The following is a description of a gene set: Mouse Gene Set: CUI_CDC1_IL11_RESPONSE_UP studied in species Mus musculus Genes positively differentially expressed in cell type: cDC1 (conventional dendritic cell type 1) upon treatment with cytokine: IL-11 in mouse lymph nodes in vivo. from publication Cui A, Huang T, Li S, Ma A, Pérez JL, Sander C, Keskin DB, Wu CJ, Fraenkel E, Hacohen N (PMID 38057668) Cytokines mediate cell-cell communication in the immune system and represent important therapeutic targets. A myriad of studies have highlighted their central role in immune function, yet we lack a global view of the cellular responses of each immune cell type to each cytokine. To address this gap, the authors created the Immune Dictionary, a compendium of single-cell transcriptomic profiles of more than 17 immune cell types in response to each of 86 cytokines (>1,400 cytokine-cell type combinations) in mouse lymph nodes in vivo. A cytokine-centric view of the dictionary revealed that most cytokines induce highly cell-type-specific responses. For example, the inflammatory cytokine interleukin-1β induces distinct gene programmes in almost every cell type. A cell-type-centric view of the dictionary identified more than 66 cytokine-driven cellular polarization states across immune cell types, including previously uncharacterized states such as an interleukin-18-induced polyfunctional natural killer cell state., and this is the list of marker genes: Wfdc17, Sri, Ccdc86, Cst3, Ldha, Gatm, Tspo, Ifitm2, Arpc1b, Ptpn1